The following is a description of a gene set: studied in species Mus musculus Any process that modulates the frequency, rate or extent of phagocytosis, the process in which phagocytes engulf external particulate material. Mouse Gene Set: GOBP_REGULATION_OF_PHAGOCYTOSIS, and this is the list of marker genes: Pros1, Colec10, Clec7a, Fpr-rs4, Lyar, Abca7 (NCBI Gene Id 27403), Btk, Adipoq, Mertk, Apoa2, Sirpa, Tlr2, Il2rg, Fpr-rs6, Cnn2, Stap1, Nod2, C2, Fcgr2b, Tub, Prkcg, Ighg2b, Ptprc, Fcnb, Cd36, Ptk2, Nckap1l, Itgav, Tgfb1, Mex3b, Cd47, Cd300a, Il2rb, Fpr2, Apoa1, Hck, Ighg1, Syt7, Scarb1, Syk (spleen tyrosine kinase), Sftpd, Alox15, Colec11, Ptx3, Appl1, Ccr7, Ager, Cd209b, Atg7, Appl2, Siglece, Rap1a, Itga2, Pparg, Rab31, Sphk1, Sftpa1 (NCBI Gene Id 20387), Lbp, Tgm2, Dnm2, Pla2g5, Cfp, Myo18a, Pot1b, Rack1, Hmgb1, Calr, Lman2, Gas6 (growth arrest specific 6), Pip4p2, Cyba, F2rl1, Arap1, Plscr1 (NCBI Gene Id 54533), Hspa8, Bcr, Plcg2, Rapgef1, Pten, Cd300lf, Ahsg (alpha-2-HS-glycoprotein), Snx3, Csk, Pycard, Dysf, Fcgr1, Il15, Ccl2, Abr, Letmd1, Atg3, Fpr-rs3, Sod1, C3, Mbl2, Mbl1, Sirpb1a, Atg5, Lrp1, Ano6, Tulp1, Fpr-rs7, Rab27a, Ptprj, Gata2, Slc11a1, Prtn3, Syt11, Camk1d, Fcer1g, Ifng, Fcgr3, Il15ra, Trem2, Rap1gap, Dock2, Myh9, Fgr